The following is a description of a gene set: Human Gene Set: GSE11864_CSF1_PAM3CYS_VS_CSF1_IFNG_PAM3CYS_IN_MAC_UP studied in species Homo sapiens from publication Hu X, Chung AY, Wu I, Foldi J, Chen J, Ji JD, Tateya T, Kang YJ, Han J, Gessler M, Kageyama R, Ivashkiv LB (PMID 18976936) Genes up-regulated in comparison of macrophages cultured with M-CSF and Pam3Cyc versus macrophages cultured with M-CSF, IFNG and Pam3Cyc. Gene expression analysis of freshly isolated CD14+ human monocytes and monocytes cultured in the presence or absence of interferon (IFN) -gamma for 24 h and then stimulated with Pam3Cys, a Toll-like receptor (TLR) 2 ligand, for 6 h. Results provide insight into mechanisms by which IFN-gamma reprograms early macrophage differentiation and subsequent response to TLR ligands., and this is the list of marker genes: DKC1, LYAR, FLNA, PRG2, FCMR, BCDIN3D, PRKCH, LITAF, C1orf53, CAPN2, GNAI3, EIF2S1, IMPA2, PTPRJ, ZNF146, SNX17, TUBB, SNHG16, MAF, ZNF528, TDG, NOL6, SEC63, PERP, ZCCHC24, GNG2, RBM17, RNF145, PSEN2, OLA1, LXN, RNF144B, LINC00857, ATL2, BCCIP, RSL24D1, GAR1, ITM2A, CRADD, TARP, HAS1, HNRNPF, SAMSN1, ILF2 (NCBI Gene Id 3608), TENM2 (teneurin transmembrane protein 2), RASAL2, PHF21A, HNRNPC, QSOX2, ADI1, PCID2, EIF3D, KCNV2, TRIM47, NME9, GALNT4, SERBP1, HSD17B3, VSTM2L, SRSF12, SPRR2C, FCHO2, NEDD9, UBQLN4, BBS1, ARPP19, FLVCR2, CSNK1G2-AS1, SIN3A, SRGN, SLC5A6, GK5, FPGS, DENR, IFRD2, SGPL1, LYRM4, PPP2CB, IMP4, ZNF174, RACK1, BMP6, NPM1, LORICRIN, DSC2, PCNX1, GALNT6, POTEKP, ATXN7L1, ABHD17C, TAS2R1, SLC44A1, ENSG00000245651, TAF9B, PA2G4, DSE, PUS1, PGRMC1, MTHFD1L, CDK2AP1, CXCL6, GMEB2, RPS8, CLIP2, SMS (NCBI Gene Id 6735), EPB41L3, TMEM242, PAM, MAOA, LRPPRC, PLK1, MB21D2, NIFK, SERPINE1, MYO1D, MCCC2, IMPDH2, LINC02260, SERTAD4BP, PPFIBP1, WFDC10A, ITPRID1 (ITPR interacting domain containing 1), HADHB, FFAR3, BRMS1L, ADGRA2, DLGAP1-AS1, PDPN, SERPINB2, LEP (leptin), SVIL, TDO2, NEK6, NOL9, TNIP1, HCG4, LAS1L, LDHA, NOC2L, MRTO4, RNF175, GTF2E1, GZMK, ZFR, SEPTIN9, B3GALT6 (NCBI Gene Id 126792), FARSB, RIPOR2, SCN9A, TEAD1 (NCBI Gene Id 8), THAP10, IARS1, SSRP1, FOLR2, ANKRD26, JPH3, MED12L, HCFC1R1, NCL, MRPL32, HEY1, TMEM255B, RHBDF1 (NCBI Gene Id 64733, rhomboid 5 homolog 1), COMT, ENSG00000229727, FAM228B, DNAAF5, PREP, SLC1A2, RPTN, APIP, SDC2, FAIM, BATF, BCL7A, TNFSF9, ZNRF1, B3GALT5, ARAF, OAZ3, RAD23B, LARS1, SNRNP40, CXCL3 (C-X-C motif chemokine ligand 3), RPIA, UBXN10, TATDN1, DDX42, RIPPLY2, GHRLOS, PCDHB14, TRAP1, MIEF1, GADD45B, GNL3, JADE3